Given this list of marker genes EN1 (NCBI Gene Id 2019), MAPK6, LINC01597, CLRN1 (clarin 1), SF3B4, PSMA1, C1orf21, TRIB1, PRDM12, KRT10-AS1, GSTT4, GAREM1, SLC38A1, PRR11, LRATD2, HOXC4 (homeobox C4), EIF4E, SCN2B, TCTN3, HOXC10, AMOTL1, ZNF385A, BORCS6, GNB4, PLXDC2, ARRDC3, STMN1, RBM18, SPRED1, FAIM2, PCDH17, LBX1, PDE3B, IRX5, FOXA1, UBAP2L, SVIL, ZNF281, HSPG2, PTMA, BMP5, TMEM81, ASIC2, AKAP1, OFCC1 (NCBI Gene Id 285807), WARS2, LSM12, CD274, KDM6A, BICDL1, GPR150, NFKBIA, EFHD1, FYN, FGF8, SPEF1, FN1, BTG1, SH2B3, INPP5F, NSRP1, KCNH7, ONECUT1, SH3BP5L, MAPK14, ADGRG4, PHOX2B, NEDD4L, PELI2, MUSK, PTTG2, VIP, IL25, ICAM1, RELA, CHST9, SETD7, HNRNPC, LMO4, THBS2, SRPK3, TIAL1, TMEM216, VIT, EPN3, STIMATE, MINDY1, WAC, ANO2, ZFAND3, TLX3, LRRN3, SFXN2, ECEL1, PPM1B, GRID2, PTK7, AMD1, TUBA1A, NPR3 (natriuretic peptide receptor 3), TACC1, RCAN1, ZMAT4, ACTN1, CACNA2D3, HOXB6, PIK3R2, F9, CELF4, FOXB1 (forkhead box B1), SLC25A28, SLC7A1, FGF13, NT5C3A, ALS2CL, NOS1, CHCHD3, SGK1, IL36A, DHRS3, MTA2, TUG1, EMCN, ZNF675, DIP2B, SPMIP6, TCF4, PCDH8, C12orf50, CBL, RBMS3, NPNT, UBR3 (ubiquitin protein ligase E3 component n-recognin 3), NEUROD2, TM9SF3, STAT3, KLHL3, FLRT3, RNF220, IL1RAPL1, RBM12B, PROSER1, RARB, MAN2C1, TMC1, MAP2K3, ARL3, CLCA3P, CCDC60, SERPINE1, HECTD2, NUFIP2, TACC2, FXYD2, CADM2, CADM1, MRRF (mitochondrial ribosome recycling factor), STC1, PLEKHA1, ORAI3, LRP5, TNFRSF11B, PHACTR3, BCL11A, RWDD3, ECHDC2, VRK1, PAK4, HOXA3 (NCBI Gene Id 3200), RYR2, NEO1, IPO4, PSMA6, MAP4K4, ETV6, AKT2 (AKT serine/threonine kinase 2), HOXA4, FLNC, TGIF1, VN1R3, PTCHD1, IL22, NFATC4, SAG, KIZ, LPXN, MTSS1, FBXO9, CXADR, MAB21L1, ZPBP2, NR4A2, TOB1, MARCKS, STRIP1, NEURL1, BTBD10, JADE1, STIP1, ADAM23, DLX5, MIR137HG, LPL, MAPK4, NDRG2, TAB2, COQ6, UGDH, NFE2L2, JPT2, CFAP161, SKA2, USP40, SATB1, MTMR11, TRPS1, GPC4, RNF43, MDP1, SUMO2, KCNJ16, CNOT2, WNT9B, BBX, MDH1, SLITRK5, ODAPH, TBCD, CNIH2, SLC38A2, C1QTNF6, AP2A1, C2CD3, DPYSL2, HMGN5, PCYOX1, BRINP3, ATP2A2, KITLG, PIM1, COCH, NPHP4, FST, FAM53C, VGLL3, N4BP1, GRIA3, VEGFD, SLC2A12, ITGA7, SNCAIP, LONRF3, EP300, ERG28, KRT8P41 (keratin 8 pseudogene 41), IRX3 (iroquois homeobox 3), SLC35A2 (NCBI Gene Id 7355), GAS7, FBXW7, KLHL13, SLC26A7, MEX3B, POLE2, ITGA2, PRRG4, TNFSF11, PRKCE, SLITRK2, FAM161B, DACH2, ST8SIA1, SHOX2, TRAF3, here is a description of the gene set: Genes having at least one occurrence of the motif NAWTTCCN in the regions spanning 4 kb centered on their transcription starting sites. This matches the STAT6 transcription factor binding site V$STAT6_01 (v7.4 TRANSFAC). studied in species Homo sapiens Human Gene Set: STAT6_01